Given this list of marker genes Hdac6, Trpm2, Epor, Selenon, Macroh2a1, Fads2, here is a description of the gene set: Mouse Gene Set: GOBP_POSITIVE_REGULATION_OF_RESPONSE_TO_OXIDATIVE_STRESS studied in species Mus musculus Any process that activates or increases the frequency, rate or extent of response to oxidative stress.